The following is a description of a gene set: Any process that stops, prevents, or reduces the frequency, rate, or extent of mast cell activation as part of an immune response. Mouse Gene Set: GOBP_NEGATIVE_REGULATION_OF_MAST_CELL_ACTIVATION_INVOLVED_IN_IMMUNE_RESPONSE studied in species Mus musculus, and this is the list of marker genes: Lilrb4a, Enpp3, Cd300a, Fer, Ptpn6